The following is a description of a gene set: Human Gene Set: GOBP_OVULATION studied in species Homo sapiens The release of a mature ovum/oocyte from an ovary., and this is the list of marker genes: AFP, GAS2, ADAMTS1, NRIP1 (nuclear receptor interacting protein 1), INHBA, NOS3, INHBB, SIRT1, MMP19, LEP, PGR, GPR149, EREG, IMMP2L, MMP2, HPGD, FOXO3